The following is a description of a gene set: Human Gene Set: GOBP_PROPIONATE_METABOLIC_PROCESS species: Homo sapiens The chemical reactions and pathways involving propionate, the anion derived from propionic (propanoic) acid, a carboxylic acid important in the energy metabolism of ruminants., and this is the list of marker genes: PCK1, PCK2, ACSS2, ACSS1, MMUT